Given this list of marker genes GZMB, UBL4B, SH3GLB1, HAX1, UBE2D3, HTRA2, PARL, BBC3, ATP5IF1, FBXW7, NMT1, PINK1, ATG13, TOMM70, UBE2L3, DNAJA1, ABLIM3, ADCY10, USP36, SIAH3, LEPROT, LRRK2, RAC2, LMAN1, HUWE1, MICALL2 (NCBI Gene Id 79778), GSK3A, BNIP3L, BAP1, FZD5, PRKN, NPEPPS, BAG3, RNF31, SREBF2, HSPA1L, ARIH2 (NCBI Gene Id 10425), CDKN2A, HPS4, MAPK8, RHOU, PRKAA1, BAG4, VPS11, TOMM7, SREBF1, C11orf65, CSNK2A2, UBL5, MAPT, UBE2J2, SAE1, here is a description of the gene set: Any process that modulates the frequency, rate or extent of establishment of protein localization to mitochondrion. Human Gene Set: GOBP_REGULATION_OF_ESTABLISHMENT_OF_PROTEIN_LOCALIZATION_TO_MITOCHONDRION species: Homo sapiens